Given this list of marker genes PALLD, TRAF3, RETSAT, NTRK3, GPC5, SAMTOR, ESRP2, F3, UBAP1, CPSF4, ZNF781, ZNF563, CCDC182, CCDC186, GPR183, AGL, UBE2M, BCAT1, DNMT3A, S1PR1, EMC6, MAP4, FCER1G, CARMIL1, CA3, MIB1, DRP2, IMMT, PIGM, KCND2, STX2, ACTR3, DMD, AZIN1, MARCHF6, NME7, CSDE1, ZNF773, PCSK5, ZNF704, here is a description of the gene set: studied in species Homo sapiens Genes predicted to be targets of miRBase v22 microRNA hsa-miR-4694-5p in miRDB v6.0 with MirTarget v4 prediction scores > 80 (high confidence targets). Human Gene Set: MIR4694_5P from publication Chen Y, Wang X (PMID 31504780)